The following is a description of a gene set: DNA Replication Pre-Initiation species: Mus musculus Mouse Gene Set: REACTOME_DNA_REPLICATION_PRE_INITIATION, and this is the list of marker genes: Anapc11, Psma5, Cdc16, Rps27a, Psmb4, Psmb6, Pole4, Pola2, Pole3, Ubc, Psmd12, Orc4, Psmb1, Cdc23, Cdc6, Psmd11, Psmd13 (proteasome (prosome, macropain) 26S subunit, non-ATPase, 13), Mcm7, Psmd7, Anapc15, Ubb, Pola1, Gmnn, Psmd2, Psmc3, Fzr1, Psmd8, Psmc1, Kpna6, Uba52, Anapc10, Mcm8 (NCBI Gene Id 66634), Adrm1, Psma1, Mcm4, Orc3, Anapc2, Dbf4, Psma6, Psmb7, Psmb2, Mcm3, Psmd1, Rpa3, Rpa1, Psmb5, Kpnb1, Ube2s, Orc2, Prim1, Anapc5, Anapc1, Cdc7, Psmd3, Ube2e1, Psmb3 (NCBI Gene Id 99155), Psmd14, Anapc7, Psmc2, Mcm2, Cdc27, Psma4, Cdk2, Ube2c, Orc5, Mcm10, Uba52rt, Pole, Anapc16, Anapc4, Psmc5, Psma2, Pole2, Psmc4, Psma3, Orc1, Mcm6, Psmc6, Cdc45, Kpna1, Psmd6, Ube2d1, Cdc26, Mcm5, Psma7, Rpa2, Cdt1, Orc6, Prim2 (DNA primase, p58 subunit)